Given this list of marker genes UBA52, PSMD12, SKP1, PSMD11, PSMD3, SEM1, UBC, RPS27A, PSMC4, RELA, PSMB6, PSMD6, PSMA2, ADRM1, PSMD14, PSMB3, PSMC6, PSMA1, PSMD8, PSMD7, PSMC2, PSMC1, PSMA3, CARD11, BTRC, MAP3K7, PSMC3, CUL1, PSMD13, PSMA6, PSMB2, REL, FBXW11, PSMB5 (NCBI Gene Id 5693), PSMD1, PSMC5, PSMA7, BCL10, NFKBIB (NCBI Gene Id 4793), NFKBIA, MALT1, PSMB7, PSMA5, PSMA4, IKBKG, NFKB1, PSMB4, PSMB1, CHUK, IKBKB, UBB, PRKCB, PSMD2, NFKBIE, here is a description of the gene set: DAG and calcium activate protein kinase C beta (PKC-beta, Kochs et al. 1991) which phosphorylates CARMA1 and other proteins. Phosphorylated CARMA1 recruits BCL10 and MALT1 to form the CBM complex which, in turn, recruits the kinase TAK1 and the IKK complex. TAK1 phosphorylates the IKK-beta subunit, activating it. The IKK complex then phosphorylates IkB complexed with NF-kappaB dimers in the cytosol, resulting in the degradation of IkB. NF-kappaB dimers are thereby released and are translocated to the nucleus where they activate transcription. studied in species Homo sapiens part of: Downstream signaling events of B Cell Receptor (BCR) Reactome Pathway: Activation of NF-kappaB in B cells